Given this list of marker genes H2BC21, CEACAM1, H2BC17, CAPG, SEC63, H2AC15, NUP98, SNX3, H2BC14, H2AC6 (H2A clustered histone 6), UFL1, RAP1GDS1, ARHGAP1, H2AC11, H2BC5, EXOSC10, MAP3K7, H2BC10, MDN1, H2AC16, INE2, H2BC8, here is a description of the gene set: Human Gene Set: HASLINGER_B_CLL_WITH_6Q21_DELETION Genes changed in the B cell chronic lymphocytic leukemia (B-CLL) with deletions in the 6q21 region. studied in species Homo sapiens PURPOSE: Genomic aberrations and mutational status of the immunoglobulin variable heavy chain (VH) gene have been shown to be among the most important predictors for outcome in patients with B-cell chronic lymphocytic leukemia (B-CLL). In this study, we report on differential gene expression patterns that are characteristic for genetically defined B-CLL subtypes. MATERIALS AND METHODS: One hundred genetically well-characterized B-CLL samples, together with 11 healthy control samples, were analyzed using oligonucleotide arrays, which test for the expression of some 12,000 human genes. RESULTS: Aiming at microarray-based subclassification, class predictors were constructed using sets of differentially expressed genes, which yielded in zero or low misclassification rates. Furthermore, a significant number of the differentially expressed genes clustered in chromosomal regions affected by the respective genomic losses/gains. Deletions affecting chromosome bands 11q22-q23 and 17p13 led to a reduced expression of the corresponding genes, such as ATM and p53, while trisomy 12 resulted in the upregulation of genes mapping to chromosome arm 12q. Using an unsupervised analysis algorithm, expression profiling allowed partitioning into predominantly VH-mutated versus unmutated patient groups; however, association of the expression profile with the VH mutational status could only be detected in male patients. CONCLUSION: The finding that the most significantly differentially expressed genes are located in the corresponding aberrant chromosomal regions indicates that a gene dosage effect may exert a pathogenic role in B-CLL. The significant difference in the partitioning of male and female B-CLL samples suggests that the genomic signature for the VH mutational status might be sex-related. from publication Haslinger C, Schweifer N, Stilgenbauer S, Döhner H, Lichter P, Kraut N, Stratowa C, Abseher R (PMID 15459216)